The following is a description of a gene set: studied in species Homo sapiens Human Gene Set: GOCC_PRESYNAPTIC_MEMBRANE A specialized area of membrane of the axon terminal that faces the plasma membrane of the neuron or muscle fiber with which the axon terminal establishes a synaptic junction; many synaptic junctions exhibit structural presynaptic characteristics, such as conical, electron-dense internal protrusions, that distinguish it from the remainder of the axon plasma membrane., and this is the list of marker genes: GRIA1, P2RY1 (NCBI Gene Id 90963), SLC6A9, NRXN2, CHRM1, GRIK4, PICK1, ERC2, SLC6A3, C1QA, DRD2, CASK, ABCC8, PCDH17, GABRA5, STX11, SYT7, KCNC2, PRRT2, ZNRF2, FLRT2, PI4K2A, RAB3GAP2, ATP2B4, APBA1, RAC1, KCNH1, KCNJ3, IGSF8, GNB5, GRM2, HTR2A, SCN10A, GRIK3, KCNA2, GRM3, PPFIA2, IGSF21, GPR151, GRIK2, GLRA3, GRIN2A, EPHB2, KCTD16, GPR158, PICALM, ADAM11, SNAP25, KCNC4, CPLX3, SLC6A11, CNTN6, GRIN2D, ADORA3, GPM6A, HCN1, SYT11, SLC5A7, EPHA4, CHRNA4, CLTB, RGS7, KCTD8, NRXN1, ADORA2A, ATP2B3, UNC13B, OTOF, AP2B1, PDE2A (NCBI Gene Id 5138, phosphodiesterase 2A), HTR1B, GPER1, KCNJ9, ADGRL1, STX1B (NCBI Gene Id 6805), CASR, ITGA3, UNC13C, ITSN2 (intersectin 2), STXBP1, GRIN3B, DENND1A, C1QC, CDH10, KCNC1, LRRC4B, SLC6A2, NECTIN1, EFNB1, CNTNAP2, PTPRD, NCSTN, AP2M1, FZD3, KCNJ8, LPAR1, SNCAIP, NRXN3, FBXO45, ERC1, KCNA1, DRD1, LPAR2, DNAJC6 (DnaJ heat shock protein family (Hsp40) member C6), EFNB2, SLC1A2, ADORA1, GRIPAP1, CTNNA2, CNTNAP4 (contactin associated protein family member 4), ADCY8, P2RX1, STX2, LRFN3, CADPS2, CLTA, NPTN, KCNQ5 (NCBI Gene Id 56479), SLC1A6, RIMS1, FXYD6, PSENEN, ITSN1, GRIK5, CTNNB1, PSEN1, ADRA2A (NCBI Gene Id 92480), SYAP1, ERBB4, RIMS3, CNTN5, GABBR1, RYK, GABRB1, RGS9, STX1A, CACNA2D1, RGS7BP, GAD2 (glutamate decarboxylase 2), UNC13A, ATP2B1, FMR1, ADAM23, CHRNA6, GRIK1, SYT1, GABRR1, PTPRS, OPRK1, APH1A, CADM3, NAPEPLD, OPRD1, CNTN1, SLC4A8, PCDH8, PSEN2, ERBB2, SLC6A4, SCRIB, KCTD12, NLGN2, SNAP91, IL31RA, KCNC3, STX19, NTNG1, CACNA2D2, NTNG2, EFNB3, CACNA2D3, SYP (synaptophysin), ZDHHC17, NAPA, GNAO1, RIMS2, CNR1